Given this list of marker genes DNAJB1, ANXA1, PDIA3P1, CUX1, PTGES3, FCGR2A, DYNLL1, STIP1, SOD1, SKIL, CCT4, HSPA8, TRA2A, here is a description of the gene set: Genes down-regulated after heat shock in peripheral lympocytes from old donors, compared to those from the young ones. Ageing results in a progressive, intrinsic and generalised imbalance of the control of regulatory systems. A key manifestation of this complex biological process includes the attenuation of the universal stress response. Here we provide the first global assessment of the ageing process as it affects the heat shock response, utilising human peripheral lymphocytes and cDNA microarray analysis. The genomic approach employed in our preliminary study was supplemented with a proteomic approach. In addition, the current study correlates the in vivo total antioxidant status with the age-related differential gene expression as well as the translational kinetics of heat shock proteins (hsps). Most of the genes encoding stress response proteins on the 4224 element microarray used in this study were significantly elevated after heat shock treatment of lymphocytes obtained from both young and old individuals albeit to a greater extent in the young. Cell signaling and signal transduction genes as well as some oxidoreductases showed varied response. Results from translational kinetics of induction of major hsps, from 0 to 24 h recovery period were broadly consistent with the differential expression of HSC 70 and HSP genes. Total antioxidant levels in plasma from old individuals were found to be significantly lower by comparison with young, in agreement with the widely acknowledged role of oxidant homeostasis in the ageing process. species: Homo sapiens from publication Visala Rao D, Boyle GM, Parsons PG, Watson K, Jones GL (PMID 12618007) Human Gene Set: VISALA_RESPONSE_TO_HEAT_SHOCK_AND_AGING_DN